Given this list of marker genes Eif6, C2cd5, Mzb1 (NCBI Gene Id 69816), Fos, Nucks1 (NCBI Gene Id 98415), Irs1, Ntrk1, Foxo1, Star, Zfp592, Epha5, Vps13c, Irs3, Ncoa5, Inhbb, Slc2a8, C1qtnf9, Rps6-ps4, Eprs1, Mup4, Mc4r, Fut7, Epha2, Appl2, Mup1, Pck1, Tyro3, Erbb2 (erb-b2 receptor tyrosine kinase 2), Igfbp1, C1qtnf12, Ceacam1, Cat, Ggcx, Ccl2, Epm2aip1, Adipor1, Igf2 (insulin-like growth factor 2), Mertk, Gcnt1, Enpp1, Meak7, Ntrk2, Socs7, Gclc, Gpr82, Trim72, Ptprf (protein tyrosine phosphatase receptor type F), Inpp5k, Epha4, Flt3, Scap, Sgk1, Irs2 (insulin receptor substrate 2), Phip, Ephb4, Ctsd, Myo5a, Flt4, Socs1, Srsf5, Vwa2, Insig2, Pak1, Bcar3, Epha8, Cad, Mapkap1, Prlh, Scly, Otop1, Slc2a1, Slc25a33, Zbtb7b, Apc, Alk, Fgfr4, Gpr21, Pklr, Rbx1, Lpin3, Grb2, Ghsr, Prkca (NCBI Gene Id 18750), Gh, Pdgfrb, Pdk2, Mapk14, Mtor, Blvra, Kit, Opa1, Galp, Lpin2, Ptprj, Dnai1, Grb10, Agrp, Rab13, Mup5, Bglap2 (NCBI Gene Id 12097), Flt1, Mapk1 (NCBI Gene Id 98012), Met, Hnrnpk, Prkci, Map2k1, Pkm, Tnfsf10, Tsc2, Pik3r3, Hmga1, Atp2b1, Ogt, Gpam, Pik3r1, Gstp1, Prkcz, Lyn, Pik3r2, Rbm4, Sirt1, Slc9a1, Pax6, Zdhhc7, Tsc1, Trarg1, Cpeb1, Eif4ebp1, Col6a1, Cry1, Insr, Hras, Vgf, Sik2, Cpeb2, Sesn2, Sos1, Mir494, Trpv4 (NCBI Gene Id 80591), Cp, Dennd4c, Pdk4, Rela, Akt1, Grb14, Oprk1, Cd2ap, Sesn3, Cdk2, Irs4, Pparg, Foxc2, Ddr2, Slc27a1, Kcnq1, Pou4f2, Fbxw8, Ucp3, Epha7, Ggh, Uchl3, Ppara (peroxisome proliferator activated receptor alpha), Serpina12, Kcnj8, Kbtbd2, Akt2, Ndel1, Mst1r, Gsk3a, Ptpn11, Fgfr1, Rab10, Egr1, Slc39a14, Xbp1, Erbb4, Ros1, Pip4k2c, Ywhag, Epha6, Ptpn2 (protein tyrosine phosphatase, non-receptor type 2), Eef2k, Rhoq, Lonp1 (NCBI Gene Id 74142), Klf15, Fgfr3, Smarcc1, Ache, H2az1, Mapk3 (NCBI Gene Id 26417), Blvrb, Appl1, Hsd11b2, Il1b, Pip4k2b, Tbc1d4, Wdtc1, Kank1, Rab8a, Khk, Zfp36l1, Plcb1, Insrr, Pten, Axl, Adipoq, Grk2, Slc2a4, Syap1, Lpl, Cul3, Prkcq, Prkdc, Ptpn1, Usf1, Sorbs1, Esrra, Pid1, Pdgfra, Max, Hadha, Akt3, Acvr1c, Cyp27b1 (NCBI Gene Id 216437), Aanat, Errfi1, Echdc3, Parp1, Sort1, Kat2b, Osbpl8, Obp2a, Prkcd, Cited1 (Cbp/p300-interacting transactivator with Glu/Asp-rich carboxy-terminal domain 1), Srsf3, Fer, Lpin1, Prkcb, Pik3ca, Ahsg, Eif4ebp2, Cry2, Sh2b2, Ephb1, Hdac9, Zbed3, Ptpra, Uprt, Foxo4, Agt, Tnf, Ins1, Retn, Sorl1, Ide, Pip4k2a, Cela2a, Pck2, Gnai2, Mup3, Erfe, Kdr, Musk, Tie1 (tyrosine kinase with immunoglobulin-like and EGF-like domains 1), Ephb2, Mir143, Rab31 (NCBI Gene Id 67353), Mtcl2, Slc27a4, Socs3, Igf1r, Cul7, Snx5, Gpt, Mfn2, Sco1, Ephb3, Abcc2, Ctsk, Gsk3b, Ror2, Trib3, Csrp3, Rarres2, Srsf6, Grb7, Epha1, Hadh, Il10, Mir423, Cav2, Sp1, Bglap3, Ankrd26, Lep, Rps6kb2, Epha3, Pfkfb1, Ddr1, Csf1r, Stxbp4, Ncl, Prkaa1 (NCBI Gene Id 105952), Col1a1, Raf1, Bcar1, Rb1, Ret, Tnfrsf11a, Adm, Nucb2, Fgfr2, Sp7, Ucp2, Gkap1 (NCBI Gene Id 80584), Alpl, Uso1, Hmgcs2, Fbp1, Got1, Pcsk9, Capn10, Egr2, Ntrk3, Inppl1, Rps6, Zfp106, Insig1, Gck, Ghrhr, Egfr, Gpld1, Stxbp3, Otc, Epha10, Srebf1, Ffar3, Cyfip1, Shc1, Src, Ptpre, Marcks, Sos2, Sgcb, Nr1h4, Nck1, Mup2, Vamp2, Rps6kb1, Mstn, Ncoa1, Ltk, Pdpk1, Tek, Bglap, Pde3b, Myo1c, Mup11, Ceacam2, Rbp4, Ins2, Tns2, Ncoa2, Ptprv (NCBI Gene Id 64447), here is a description of the gene set: Mouse Gene Set: GOBP_RESPONSE_TO_INSULIN Any process that results in a change in state or activity of a cell or an organism (in terms of movement, secretion, enzyme production, gene expression, etc.) as a result of an insulin stimulus. Insulin is a polypeptide hormone produced by the islets of Langerhans of the pancreas in mammals, and by the homologous organs of other organisms. studied in species Mus musculus